Given this list of marker genes HADH, HADHA, KCNJ11, AKT2, HNF1A, UCP2, DOLK, GCK, ACADVL, ABCC8, CPT2, HADHB, SLC25A20, CPT1A, HNF4A, here is a description of the gene set: A decreased concentration of glucose in the blood associated with a reduced concentration of ketone bodies. species: Homo sapiens Human Gene Set: HP_HYPOKETOTIC_HYPOGLYCEMIA Hypoketotic hypoglycemia